The following is a description of a gene set: The presence of an abnormal curvature of the vertebral column. Abnormal curvature of the vertebral column Human Gene Set: HP_ABNORMAL_CURVATURE_OF_THE_VERTEBRAL_COLUMN studied in species Homo sapiens, and this is the list of marker genes: NUP85, SMC5, STAT3, KCNAB2, TRAIP, MARS1, HSD17B4, KIAA0586, CRLF1, COL6A1, MBD5, TPM3 (tropomyosin 3), DPYSL5, NOTCH2NLC, NDUFAF1, SNAP25, MYH3, GABBR1, PDE6D, PCYT1A, AFG2A, ACP5, VPS37A, MED25, HDAC4, ABCC6, TGFB3, TMEM94, OCRL, MFN2, MPLKIP, TRAPPC11, ERCC3, CUL7, IKBKG, MAP3K20, RTN2, CDK13, SMAD4, FLRT1, APTX, OXR1, DEAF1, BPTF, KCNJ2, DLL3, SH3PXD2B, TBX5, NONO, HIRA, THSD4, PRKG1, ITGA7, DSTYK, FOXRED1, EMC1, UNC80, SACS, NEDD4L, B9D1, SEC23A, SLC52A2, SLC9A6, TBC1D20, IGF2, SYT2, FKBP14, PIGY, XYLT1, GFM2, SPTBN1, COMP, CD96, MYMK, SCN1A, MPZ, B3GALT6 (beta-1,3-galactosyltransferase 6), P3H1, TYMS, GPC4, FBLN5, SNUPN, LBR, ERCC4, ALG11, MYL11, COL11A1, ARID2, RETREG1 (NCBI Gene Id 96119), AFF3, CHRNA1, HTT, DOK7, FUT8, YARS2, LIPE (NCBI Gene Id 3991), COG8, PPIB, MED12, MYOD1 (NCBI Gene Id 4654), USP7, PPP1R21, HTRA1, NODAL, GPR101, SLC52A3, GLE1, DLK1, SYNE1, SOX11, RAI1, KY, MTMR14, BANF1, MOGS, FANCC, SPTLC1, USP9X, SLC2A10, SPARC, MAP1B, CENPT, MMP2, ACTN2, NSDHL, AIP, SLC39A13, SLC12A6, FARSB, TBX2, ZEB2, KMT2A (lysine methyltransferase 2A), LETM1, SLC6A1, BDNF, COQ4, SLC10A7, CTNND2 (catenin delta 2), CRIPTO, MAPK8IP3, BBS1, EXOSC5, OTUD7A, TAF1, RAC1, NGLY1, ZNF407, ATL1, FAT4, TMEM165, TGFB2, VRK1, ZIC2 (Zic family member 2), FANCI, NKX6-2, NUP107, TBX4, SERPINH1, TLK2, MYBPC1, WNT5A, POMT1, MTRR, SLC25A21, RECQL4, NKAP, CRELD1, ADGRG6, MYO1H, HS2ST1, CYP27A1, SMG9, MESD, MYH7, GGPS1 (geranylgeranyl diphosphate synthase 1), RAB3GAP2, SLC25A22 (NCBI Gene Id 79751), CLIC2, NFIX, USB1, WDR45B, YIF1B, ARL6IP6, TCF20, VMA21, ADAMTS10, SLC30A9 (NCBI Gene Id 10463), BGN, COPB1, BCR (NCBI Gene Id 729775), DHX30 (NCBI Gene Id 22907), FGF10, BRAF, GRIA3, SGCA, BMP4, NFU1, CANT1, STAG2, ZIC1, FGFRL1, VPS13B, TMEM231, DDX3X, PPP1R15B, PDZD8, SCN4A, IGBP1, SOX5, CAPN3, GFAP, GNE, LGI3, SPTAN1, CCM2, H3-3B, CADM3, PPP2R3C, TUBB3, SLC35A3, PUS1, ZDHHC9, PHF8, CRPPA, MEG3, ZBTB20, EIF2AK3, MMP23B, MAP2K1 (NCBI Gene Id 5604), TRAPPC2, SHROOM4, FMR1, CHKA, FHL1, TBCK, PI4KA, VANGL1, SIM1, KLLN, ALDH3A2, RNF125, FANCA, CDON, ITGB6, DKK1, GPC3, EP300, ACTG1, PIEZO2, AGRN, FLVCR1, COL2A1, KLHL41, SHOX, CDC42BPB, TTN, APC, PLOD2, SEC23B, GLB1, LUZP1, IGHMBP2, DDR2, ABL1 (ABL proto-oncogene 1, non-receptor tyrosine kinase), GZF1, MED12L, MKRN3, PSMD12, HYCC1 (hyccin PI4KA lipid kinase complex subunit 1), CAMSAP1, PRG4, GNPAT, H4C9, SATB2, PEX5, TMEM38B, KMT2E, CEP104, GAN (gigaxonin), PIGV, ACBD6, EHMT1, RAB5IF, ERCC6, LIMK1, TTC5 (NCBI Gene Id 91875), SH3TC2, SBF1, SLC35B2, SALL4, CPLX1, C1R, NEFL, SRY, SYT1, DCHS1, NOP10, HK1, SIGMAR1, PYCR1 (pyrroline-5-carboxylate reductase 1), GCH1, VPS35L, ATP6AP2 (ATPase H+ transporting accessory protein 2), PRDM13, UPB1, ARSK, ATP6V1B2, DNM1L, HNRNPH2, GNS, COL9A1, NUP88, FGFR3, RPL13, MPV17, CYP7B1 (cytochrome P450 family 7 subfamily B member 1), GOSR2, RUNX2, ERCC1, EXT2, RRM2B, RAD51C, MEOX1, PIGL, RMRP, LMOD3, PHACTR1, PPP1CB, TBX6, ALG2, ALG13, KCNQ1OT1, TUBB4A, PIGG, RNU7-1, GALNS, POLR3A, SCYL2, TARS1, GLS, WASHC5, ASH1L, GJB1, RAD51, MFAP5, COL6A2, CCDC32 (NCBI Gene Id 90416), SON, RRAS2, UBE2T, SPART, TGFBR2, CRKL, ATRIP, LSM11 (LSM11, U7 small nuclear RNA associated), GNAQ, ARMC9, INTS1, ACVR1, LAMA2, ALMS1, COL25A1, SGCG, KMT2C, GNA11, SSR4 (NCBI Gene Id 6748), NUS1, WDR81, ALG1, CDK19, MGAT2, KLC2, MVK, JMJD1C, BRF1, WRAP53, CDKL5, FANCF, NDUFAF4, VPS37D (VPS37D subunit of ESCRT-I), EFNB1, HNRNPA2B1, MAPK1, MESP2, SEMA3E, NEK1, VAMP1, TRPM3, TGFB1, ITPR1, MADD, IL6ST, SLC35A2, SNRPB, HLA-B, PHKA1, RNU12, ELN, TTC19, FANCD2, NDRG1, PIK3CA, CHD8, HPGD, ZNF423, HGD, EED, NCF1, ITCH, COLQ, HEY2, CDC42, FBN1, ASAH1, MBTPS2, PTCH2, GH1, CHMP1A, BICRA, NEU1, ARPC5, DUX4, KIF22, CFAP410, CSGALNACT1, XRCC2, WNK1, FLNA, AKT1, DNA2, PORCN, RBM8A (RNA binding motif protein 8A), GFPT1, MEGF10, ERMARD, PAX6, PTCH1, DDHD1, ATP6V1A, POLR1A, TWIST1, CASK, DICER1, RTL1, KCNA1, XYLT2, TBL2, SOX9, SDHD, SPTSSA, RAPSN, HINT1, ASXL2, SETBP1, MGME1, AIMP1, GBA2, BRD4, LARGE1, APC2, GNPTG, ACAN, LZTR1, UBA1, CHRND, NEPRO, PDPN, FLAD1, IPO8, FOXP2, LMNB1, SLC18A3 (NCBI Gene Id 6572), CPLANE1, RAB3GAP1, NOTCH3, HACE1, DNAJC6, CCBE1, OCA2, NAA20, CHST11, AP1S2, MAN2B1 (mannosidase alpha class 2B member 1), HERC1, SLC37A4, SMAD3, FAM111B, HACD1, NELFA, CARS1, RFC2, ERCC2, CHST14, KANSL1, COX8A, TMEM147, GTF2IRD2, MPL, TCTN1, TERC, ZMYM2, AUTS2, ARPC4, ASCC3 (NCBI Gene Id 63921), KCNN3, TTPA, AIFM1, BICD2, COL6A3, SLC25A24, SNORD116-1, UBTF, POU4F1, DES, FANCL, TRAF7, SVIL, PIBF1, AHSG, RERE, SPTBN4, TCTN2, OBSL1, SLC25A46, TMEM138, DEGS1, TONSL, DLG4, NXN, EIF4H, RPGRIP1L, LMNA, CASZ1, CHRNE, AHDC1, SH2B1, MYO18B, FXN, TOR1A, MORC2, OTUD6B, FLII, CEP152, KRAS, LSS, DPAGT1, PRKCZ, KCNT1, IDUA, PPP1R12A, RIT1, MAP3K7, HYAL1, DNMT3A, PPP2R5D, RPS6KA3, NACC1, COQ2, WDR11, GORAB, TMEM216, LMX1B, POLA1, PLEC, ERGIC1, DYM, ADAR, PIK3CD, HPDL, UBAP2L, SPRTN, FZD2, COQ6, MASP1, FIG4, ATP2B1, CCDC22, BUD23, IFT74 (NCBI Gene Id 80173), TMEM43, SCN9A, CBY1, FARSA, TTI2, PRPS1 (phosphoribosyl pyrophosphate synthetase 1), SRCAP, DPF2, COMT, C1S, AP1G1, ELP1, ZFX, CCND1, SMARCE1, ERI1, GRB10, PYROXD1, TPM2, CSF1R, SPG7, RNF13, ADCY5, EXOC6B, MINPP1, ARFGEF2, TGDS, PODXL, SFRP4, PRKAR1A, NF1, MAD2L2, RAB23, BMP1, TRIP11, SMS, NHP2, KCNJ6, HNRNPU (NCBI Gene Id 3192), PCGF2, PTEN, TRPV4, COLEC11, PIGS, PISD, BRCA2, FGFR1, KDM6A, GARS1, RIGI, HNRNPK, SOS1, PLK4, COL1A2, PTH1R, NPM1, BAG3, PET100 (PET100 cytochrome c oxidase chaperone), FKBP6, PDCD10, NDN, FOXE3, LIFR, SIN3A, PLOD1, LRP5, NEB, TMTC3, AARS1, SNORD115-1, FRG1, NPAP1, SETD5, ATP6V1E1, LIG4, ALS2, LAMB2, AHI1, SOS2, PPM1D, RRAS, TCF4, MAT2A, VAC14, QRICH1, EMD, BRIP1, TNNT1, PSAT1, PIGU, PIGT, SPRED1, CNOT2, ZMIZ1, GALC, CSNK2A1, SELENON, BIN1, H1-4 (H1.4 linker histone, cluster member), PRDM5, NPR2, CCDC28B, CDH11, THPO, PIGW, MYPN, SF3B4 (splicing factor 3b subunit 4), MIA3, SLC25A1, DMPK, MRAS, ATP7A, TNNI2, KCNH1, ZNF469 (zinc finger protein 469), EBF3, PWRN1, AK9, POGZ, EFEMP1, TK2, TANC2, SAMHD1, PIGA, DAG1, TBL1XR1, MAGEL2, NDUFA12, SCUBE3, TFE3, COL5A1, KATNIP, SCN2A, PNKP, STIL, ARL13B, TRAPPC4, RNASEH1, DYSF, GUSB, KIF1A, COL27A1, TBC1D24, ALG12, GABBR2, HES7, POLE, ANO5, PRX, STAC3, PLEKHG5, INPP5K, TUBGCP6 (NCBI Gene Id 85378), INPP5E, ADAMTS2, COL1A1, ROR2, IMPDH2, PUM1, DISP1, SURF1, SPEG, SDHC, CHAT, AIMP2, SIX3, CDC45, FBN2, UBE3A, ASXL3, NDUFAF6, DHCR7, PTPN11, SMARCA4, VPS33A, PYCR2 (NCBI Gene Id 29920), KCNQ2, NTNG1, LAGE3, EZH2, PMP22, MAF, IDH2, TOGARAM1, KIF5A, ALG14, METTL27, SLC5A7, SEMA5A, GDF5, FN1, DLL1, EBP, FBXL4, FA2H, MAPKBP1, ACTB, SLC39A14, GET4 (NCBI Gene Id 51608), RBBP8, FANCM, NAA10, RAB18, RAF1, FUZ, MBTPS1, ALDH18A1, BAZ1B, IDS, ATP6V0A2, B3GLCT, MSTO1 (misato mitochondrial distribution and morphology regulator 1), RIPPLY2, MATN3, GLI2, POP1, SNX14, SLC12A5 (solute carrier family 12 member 5), TELO2, MEIS2, MYO9A, TERT, FLCN, SMARCA2, SF3B2, GDF3, MYH2, LHX3, PMM2, KAT6B (lysine acetyltransferase 6B), POLG, NPHP1, PLAAT3, CAVIN1, IDH1, DCC, FLNB (filamin B), KRIT1, PIK3R2, SUPT16H (SPT16 homolog, facilitates chromatin remodeling subunit), ZMPSTE24, TMCO1, CCDC47, SGMS2, CIC, CHST3, RET, PGM3, ANKRD17, ECEL1, RASA2, NF2, CEP120, LFNG, SYNJ1, TNFRSF11B, CBL, RBM10, ERCC8, SRD5A3, USP8, ARID1A, CHD3, UPF3B, LTBP4 (latent transforming growth factor beta binding protein 4), GTF2I, ARL6, DMD (NCBI Gene Id 548327), SCAF4, NEK9, MEGF8, GBA1, MCM3AP, MANF, COL11A2, MYMX, FUCA1, DYRK1A, NDP, MRPS34, GNAS, COL5A2, NSD1, COL3A1, GABRD, B4GALT7, CTSK, GTF2H5, ARSB, ALG9, RYR1, WLS, RNASEH2A, DYNC2H1, CBS, SETX, SMARCB1, PWAR1, POR, HMGA2, DLX5, ACADS, DDX59, TTC21B, FKRP, PAX3, TFAP2A (transcription factor AP-2 alpha), GTF2E2, ANTXR1, TGFBR1, ARID1B, RNASEH2C, SMC1A, POLR3GL, SGSH, PRKD1, FGF8, USF3, FILIP1, AEBP1, ARSL, NOTCH2, GLIS3, NDUFAF5, TBX1, DKC1, TPI1, IRF6, TRIO, WNT3A, PDGFRB, STX1A, CC2D2A, RBCK1, TMEM270, KCNJ5, MUSK (muscle associated receptor tyrosine kinase), CAPRIN1, RTEL1, PLP1, SMAD2, MAPT, CCDC8, GP1BB, MYLK, GSC, TINF2, SATB1, ATAD1, CUL4B, GJA5, EGR2, DNAJC30, RYR3, HSPG2, RNU4-2, NKX3-2, CFL2, LTBP3, PHF6, FGD1, NR4A2, CHRNB1, RREB1, KIF21A, ARX, EXTL3, B3GAT3, SLC16A2, CTCF, PRUNE1, HSPD1, PACS1, PRKG2, MYH11, GNPNAT1, SPEN, PLCH1, TBCD, GDF6, TCF12, MARS2, CEP41, CLCN4, ABHD16A, JARID2, CLCF1, TRIP4, ALG6, GNPTAB, NARS1, PDE4D, UBE4B, HRAS, DVL1, CEP290, TAF4, VDR, SDHB, P4HTM, ATRX, FKBP10, TMEM218, L1CAM, LMNB2 (NCBI Gene Id 84823), FOXH1, ABCC9, PIK3C2A, GAS1, SLC25A42, TCTN3, SEC24C, ALX3, MTMR2, DVL3, TMEM63C, POMT2, DSE, H19, FANCB, UFC1, LOX, RSPRY1, KIAA0753, PAX2 (NCBI Gene Id 5076), RUSC2 (RUN and SH3 domain containing 2), KMT2D, CHRM3, DCX, SLX4, TGIF1, SLC1A2, RPL10, NRAS, SMARCAL1, CNP, FARS2, COLEC10, GMPPB, RNASEH2B, SAMD9, ARVCF, COG1, DACT1, COL12A1, P4HB, SYNE2 (spectrin repeat containing nuclear envelope protein 2), GJC2, HNRNPA1, ADAMTSL2, YWHAG, SMARCD1, ACTA2, HMGB3, JPH1, WT1, JAG1, FBXO28, PDE11A, COL10A1, MKS1 (MKS transition zone complex subunit 1), SKI, RPL11, UFSP2, POMK, TBCE, POLD1, CCN6 (cellular communication network factor 6), PUF60, KDELR2, BRCA1, DPM2, KBTBD13, NRCAM, CSPP1, RIN2, FUS, PRORP, DNM2, GRIN1, HECTD4, LARP7, RAB33B, HNRNPH1, CHD7, PHKG1, DDX6, TUBGCP4, PARN, B4GALNT1, ADAMTS15 (NCBI Gene Id 219807), SBF2, MLXIPL, SNRPN, CTDP1, DNMT3B, PIEZO1, PLCB1, NSD2, CREBBP, NRXN1, CACNA1S, VCP, NSUN2, WIPI2, ROBO3, FLI1, SPRED2, SEC24D, PIGQ, CTBP1, MMP14, CAMTA1, FKTN, RFWD3, MYL2, SMARCC2, TMEM237, GDAP1, MYF5, NCAPG2, MTRFR, TREX1, SP7, IARS2, TNNT3, STAG1, LONP1, HUWE1 (HECT, UBA and WWE domain containing E3 ubiquitin protein ligase 1), FOXC2, KLHL7, PAX7, ZMYM3, FANCE, INPPL1, ACTA1, RBM28 (RNA binding motif protein 28), NIN, TRRAP, IFIH1, UFD1, TUBA1A, ZC4H2, SHH, DPP6, TRAPPC12, VPS53, ERLIN1, LTBP1, CTC1, HERC2, DDRGK1, PCNT (NCBI Gene Id 9346), PAPSS2, SPG11, HSPB8, MMP13, SORD, B9D2, CENPE, MECP2, CLCN7, HGSNAT, SLC26A2, BAP1, ARL3, LYSET (lysosomal enzyme trafficking factor, NCBI Gene Id 26175), FGFR2, POMGNT1, ESCO2, SUZ12, NEMF, ATAD3A, HNRNPR, WNT1, LEMD3, GJA8, SUFU, PTDSS1, FOXG1, SLCO2A1, DUX4L1, GTPBP2, GAD1, PQBP1, NALCN, SHMT2, ARF1, PRDM16, ADNP, CAPN1, AGA, TTI1, DHX37, PAFAH1B1, IQSEC2 (IQ motif and Sec7 domain ArfGEF 2), PALB2, PGAP2, GTF2IRD1, CTNNB1, PIGO, FANCG, BCOR, GNB2, IHH, PPP2R1A (NCBI Gene Id 5518), SOX4, PLOD3, PNPT1, SLITRK2, NDUFS3, NECTIN1, MAP2K2, AMER1, BMPR1B, TMEM67, OFD1, COL13A1, ATR, LRP4, JAG2, AFG2B (NCBI Gene Id 80051), PLAA, CLIP2, SIL1, RAC3, CLP1, ERLIN2, NMNAT1, ANKRD11, FGD4, TRMT10A, H4C5, CACNA1G, CRTAP, MTTP (microsomal triglyceride transfer protein), ATN1, HYLS1, PEX7, HMBS, IFT172, SMCHD1, ATG7, CHRNG, TRPS1, KNSTRN, RNF113A, PGAP3